Given this list of marker genes Trp53, Zfp385a, here is a description of the gene set: This event has been computationally inferred from an event that has been demonstrated in another species.<p>The inference is based on the homology mapping from PANTHER. Briefly, reactions for which all involved PhysicalEntities (in input, output and catalyst) have a mapped orthologue/paralogue (for complexes at least 75% of components must have a mapping) are inferred to the other species. Reactome Pathway: Transcriptional  activation of  cell cycle inhibitor p21 electronically inferred by orthology from the curated human pathway part of: Transcriptional activation of p53 responsive genes   studied in species Mus musculus